The following is a description of a gene set: species: Mus musculus Mouse Gene Set: GOBP_CELL_FATE_SPECIFICATION The cellular developmental process involved in cell fate commitment in which the cell is designated to follow a developmental path, unless they receive extrinsic cues that direct an alternative fate., and this is the list of marker genes: Dmrt3, Dbx1, Myt1l, Tead4 (TEA domain family member 4), Smo, Ntrk3, Eomes, Nfia, Pou1f1, Etv2, Evx1, Sox9, Gsc, Gatad2a, Sufu, Nkx2-3, Mesp1, Tbx22, Nkx2-2, Mta3, Otx2, Pou4f1, Ehmt2 (NCBI Gene Id 52041), Tbx4, Foxi3, Tbx3, Itgb1, Hnf1b, Isl2, Apc2, Ptch2, Nfix, Fzd7, Ihh, Pou3f2 (NCBI Gene Id 77364), Shh, Hoxa13, Lbx1, Tbx5, Sox6, Mta2, Tbx1, Six2, Nanog, Bmpr1a, Hdac1, Sfrp2, Dkk1, Nodal, Tbr1, Hoxd10, Smad4, Gli2, Hdac2, Six1, Sox1, Hoxc10, T, Nkx6-1, Wnt3a, Tbx19, Olig2, Pax6, Notch1, Rbpj, Apc, Hoxa11, Rbbp7, Chd4, Psen2, Sox18, Mta1, Isl1, Mir450b, Pax2, Tlx3, Gatad2b, Flvcr2, Sox17, Nkx6-2, Sox2, Tbx18, Tbx15, Psen1, Prdm14, Dhh, Tbx10, Esrp1, Tbx20, Atoh1, Rbbp4, Myl2, Tenm4, Dll1, Foxa1, Cdon, Lmo4, Pou5f1, Eya1, Mga, Fgfr1, Tbx6, Tbx2, Ascl1, Ptch1, Fgf2, Tbx21, Gfi1, Mnx1, Ctnnb1, Gli3, Olig3, Fkbp8, Lhx3, Dmrta2, Mbd3, Fev, Nfib, Foxa2, Gsx2